The following is a description of a gene set: The nail disease paronychia is an often-tender bacterial or fungal hand infection or foot infection where the nail and skin meet at the side or the base of a finger or toenail. The infection can start suddenly (acute paronychia) or gradually (chronic paronychia). Human Gene Set: HP_PARONYCHIA Paronychia species: Homo sapiens, and this is the list of marker genes: RETREG1, ADAM17, LAMC2, STAT3, KRT6B, BLM, LAMB3, KIF1A, SLC39A4, KRT16, CEBPE, SCN9A, WNK1, LAMA3, KRT17, KRT6A